Given this list of marker genes XPO1, RANBP9, SRSF1, GCN1, PRKDC, SNRPB, POLR2A, TRIM28, MCM2, MSH6, XPOT (NCBI Gene Id 11260), PCNA, PABPC1 (poly(A) binding protein cytoplasmic 1), SUPT16H, H3-4, NUP93, MCM5, NASP, SRSF3, PARP1, SMC1A, IPO7, MYBBP1A, RANBP2, CAND1, TOP2A, C1QBP, DDX5, SMC3, CHD6, DDX17, KPNB1, EFTUD2, H2AC6, SRSF2, MSH2, GEMIN5, LMNB1, POLR2B, NOP56, SNRPD3, H2BC17, MCM6, RUVBL2, here is a description of the gene set: Proteins interacting with AIRE, based on massspectroscopy analysis of co-immunoprecipitates in 293T cells (embryonic kidney). Aire induces the expression of a battery of peripheral-tissue self-antigens (PTAs) in thymic stromal cells, promoting the clonal deletion of differentiating T cells that recognize them. Just how Aire targets and induces PTA transcripts remains largely undefined. Screening via Aire-targeted coimmunoprecipitation followed by mass spectrometry, and validating by multiple RNAi-mediated knockdown approaches, we identified a large set of proteins that associate with Aire. They fall into four major functional classes: nuclear transport, chromatin binding/structure, transcription and pre-mRNA processing. One set of Aire interactions centered on DNA protein kinase and a group of proteins it partners with to resolve DNA double-stranded breaks or promote transcriptional elongation. Another set of interactions was focused on the pre-mRNA splicing and maturation machinery, potentially explaining the markedly more effective processing of PTA transcripts in the presence of Aire. These findings suggest a model to explain Aire's widespread targeting and induction of weakly transcribed chromatin regions. species: Homo sapiens from publication Abramson J, Giraud M, Benoist C, Mathis D (PMID 20085707) Human Gene Set: ABRAMSON_INTERACT_WITH_AIRE